The following is a description of a gene set: Reactome Pathway: Potassium Channels part of: Neuronal System studied in species Homo sapiens Potassium channels are tetrameric ion channels that are widely distributed and are found in all cell types. Potassium channels control resting membrane potential in neurons, contribute to regulation of action potentials in cardiac muscle and help release of insulin form pancreatic beta cells.<br>Broadly K+ channels are classified into voltage gated K+ channels, Hyperpolarization activated cyclic nucleotide gated K+ channels (HCN), Tandem pore domain K+ channels, Ca2+ activated K+ channels and inwardly rectifying K+ channels., and this is the list of marker genes: KCNMA1, GNG13, KCNA7, GNG8, KCNMB3, GABBR1, KCNN3, HCN1, KCNAB3, KCNG2, GNGT1, GNGT2, KCNC1, KCNAB1, KCNK16, ABCC9, KCNJ1, KCNV1, KCNV2, KCNMB1, KCNK9, KCNJ15, KCNK1, KCNK17, KCNS2, GNB4, KCND1, GNG10, KCNQ2, GNB3, KCNJ11, KCNK2, GNG11, GNB1, KCNN4, KCNJ6, KCNF1, GABBR2, KCNJ5 (potassium inwardly rectifying channel subfamily J member 5), KCNK18, GNB5, KCNB1, HCN2, KCNAB2, KCNH2, KCNC2, KCNG4, GNG4, KCNQ1 (NCBI Gene Id 3784), GNG3, KCNQ3, KCNMB2, KCNJ3, KCNK7 (potassium two pore domain channel subfamily K member 7), ABCC8, KCNK6, KCNA1, KCNH6, KCNS1, GNG12 (NCBI Gene Id 55970), GNG2, KCNB2, GNB2, KCNH1, KCNA10, KCNQ4, KCNH7 (NCBI Gene Id 90134), KCNJ14, KCNK3 (NCBI Gene Id 3777), HCN4, KCNJ2, KCNC4, KCNQ5 (NCBI Gene Id 56479), KCNG1, KCNJ9, KCNA4, KCNA6, GNG5, KCNH4, KCNA2, KCNMB4, KCNS3, KCNH8, HCN3, KCNH3, KCNK10, KCNA3, KCNJ16, KCNN1, KCNJ10, KCNN2, KCND3, KCND2, KCNK4, KCNJ12, KCNC3, KCNH5, KCNK13, KCNJ8, GNG7, KCNA5, KCNG3, KCNJ4